Given this list of marker genes PRR15, H2AC6, TCF4, RASGRP1, RNF130, FAM162A, ANP32A, MSANTD3, TAP2, DMRT2, CLTB, DMXL2 (Dmx like 2), MYC, RASSF5, ABHD2, ITM2C (NCBI Gene Id 9523), P2RX5, EID1, ADAM10 (NCBI Gene Id 102), CARNMT1, ELOVL5, C11orf96, MRPS24, IFNGR1, BMPR1A, C19orf12, CSK, LDLRAD4, GSTO1, CAMSAP2, RPH3A, TLE3 (NCBI Gene Id 7090), SERPINI1, CDK6, SEMA4B, GLCE, NCF4 (neutrophil cytosolic factor 4), UQCRB, OCLN, PPARGC1B, CSF2RB, GDPD1, DTWD1, IL6R, LINC00342, CCNE1, ELOVL4 (ELOVL fatty acid elongase 4), H2AC18, APPL1 (NCBI Gene Id 26060), PKIG, TMED3, UBE2B, ZC3HAV1, ARHGEF3, HOXB7, here is a description of the gene set: species: Homo sapiens Human Gene Set: ZHAN_MULTIPLE_MYELOMA_CD1_AND_CD2_DN To better define the molecular basis of multiple myeloma (MM), we performed unsupervised hierarchic clustering of mRNA expression profiles in CD138-enriched plasma cells from 414 newly diagnosed patients who went on to receive high-dose therapy and tandem stem cell transplants. Seven disease subtypes were validated that were strongly influenced by known genetic lesions, such as c-MAF- and MAFB-, CCND1- and CCND3-, and MMSET-activating translocations and hyperdiploidy. Indicative of the deregulation of common pathways by gene orthologs, common gene signatures were observed in cases with c-MAF and MAFB activation and CCND1 and CCND3 activation, the latter consisting of 2 subgroups, one characterized by expression of the early B-cell markers CD20 and PAX5. A low incidence of focal bone disease distinguished one and increased expression of proliferation-associated genes of another novel subgroup. Comprising varying fractions of each of the other 6 subgroups, the proliferation subgroup dominated at relapse, suggesting that this signature is linked to disease progression. Proliferation and MMSET-spike groups were characterized by significant overexpression of genes mapping to chromosome 1q, and both exhibited a poor prognosis relative to the other groups. A subset of cases with a predominating myeloid gene expression signature, excluded from the profiling analyses, had more favorable baseline characteristics and superior prognosis to those lacking this signature. Genes commonly down-regulated in CD-1 and CD-2 clusters of multiple myeloma samples and which were higher expressed in the CD-1 group. from publication Zhan F, Huang Y, Colla S, Stewart JP, Hanamura I, Gupta S, Epstein J, Yaccoby S, Sawyer J, Burington B, Anaissie E, Hollmig K, Pineda-Roman M, Tricot G, van Rhee F, Walker R, Zangari M, Crowley J, Barlogie B, Shaughnessy JD Jr (PMID 16728703)